The following is a description of a gene set: species: Mus musculus Mouse Gene Set: GOBP_REGULATION_OF_SUBSTRATE_ADHESION_DEPENDENT_CELL_SPREADING Any process that modulates the frequency, rate or extent of substrate adhesion-dependent cell spreading., and this is the list of marker genes: Carmil1, Cspg5, Olfm4, Itgb1bp1, P4hb, Braf, C1qbp, Ap1ar, Kank1, Nedd9, Tesk1, Itgb3, Dab2, Cib1, Rac3, Efna5, S100a10, Meltf, Coro1c, Dock1, Nrp1, Fbln1, Spry4 (NCBI Gene Id 328944), Cass4, Rreb1, Rcc2, Unc13d, Crkl, Dock5, Pkp2, Crk, Bcar1, Has2, Cdc42, Apoa1, Dbn1, Lims1, Ilk, Enpp2, Flna, Fermt2, Prex1, Myoc, Calr, Pdpn, Rac1, Dmtn, Arpc2, Actn4, Ptk2, Abl1, Triobp, St6gal1, Dnm2, Tacstd2, Lims2, Postn, Mdk, Myadm